Given this list of marker genes Clip3, Zfp213, Fam210a, Ndrg1, Alg11, Gm17455, 4930486L24Rik, Nfia, Tanc2, Ube2z, Cend1, Acbd6, Ubiad1, 2810021J22Rik, Slc17a6, Tmem178, Lcmt2, Rab30, Mtf2, Poln, Xirp1, Igsf21, Gja8, Egfr, Sox11, Mllt3, Camk1d, Rab7, Rhoj, Glis1, Chd2, Ano5, Kdm3a, Clcc1, Golga5, Wdr64, Zfpm2, Rp1, Bicd2, Cthrc1, Rad21, Stt3b, here is a description of the gene set: Mouse Gene Set: MIR_6897_3P studied in species Mus musculus from publication Chen Y, Wang X (PMID 31504780) Genes predicted to be targets of miRBase v22 microRNA mmu_miR_6897_3p in miRDB v6.0 with MirTarget v4 prediction scores > 80 (high confidence targets).